Given this list of marker genes GNG12, GNG13, ADCY1, FSHR, VIPR1, CRHR2, ITGA5, GNG3 (NCBI Gene Id 2785), PDE1B (phosphodiesterase 1B), GNAI3, HTR4, GPR32, ADORA2B, ADCYAP1, ADCY4, PTHLH, ADCY6, PTGDR, PTGER2, LHCGR, CALCB, GNGT1, ADRB1, ADCY3, GPR25, PTGIR, PRKAR2B, GRK3, GLP1R, CGA, MC2R, GNG7, PTH2R, MC5R, HTR6, PRKACB, POMC, GNG11, PTGER4, PDE3A, PDE7B, RAMP3, TAAR5, TAAR1, GPHA2, GIPR, RXFP2, ADCY9, GPR27, ADCY8, PDE8B (phosphodiesterase 8B), GRK6, GNG5, ARRB2, GPR84, ADCY2, CRH, SCTR, RXFP1 (relaxin family peptide receptor 1), SHC1, FSHB, PDE7A, GPR176, ADORA2A, MC3R, PRKACG, LHB, GNG2, DRD5, FN1, PRKAR2A, GCGR, GNAT3, TSHB, HTR7, GPR83, GPER1, PDE8A, TAAR6, GNB2, SRC, ADCYAP1R1, RLN3, GNG8, PDE1A, GIP (gastric inhibitory polypeptide), CRHR1, GNGT2, MC4R, ITGB1, PDE4D, PRKAR1A, GPR15, PDE3B, ADRB2, PDE4A, GPR39, GLP2R, ARRB1, PRKAR1B, GNAS, GRK2, TAAR2, GPR45, AVP, GPR20, GPBAR1, CALCA, CALCR, GHRH, NPS, GNAI1, GNG10, TAAR9, MC1R, CYSLTR2, PDE11A, VIP, PTH, AVPR2, RAMP2, SCT, NPSR1, GHRHR, ADCY7, PDE2A, GNB4, GNB3, P2RY11, GPHB5, CALCRL, PDE4C, GNAZ, IAPP, ADCY5, ADRB3, PTH2 (NCBI Gene Id 113091), GNG4, GNB1, GPR150, RLN2, DRD1, PTH1R, RAMP1, HRH2, GNAI2, ADM, VIPR2, ADM2, GNB5, TSHR, GRK5, PDE10A, GCG, TAAR8, PRKACA, INSL3, here is a description of the gene set: G alpha (s) signalling events Human Gene Set: REACTOME_G_ALPHA_S_SIGNALLING_EVENTS species: Homo sapiens